Given this list of marker genes Anapc15, Anapc10, Anapc16, Cdc26, Anapc7, Fzr1, Ube2s, Anapc4, Cdc23, Anapc5, Ube2e1, Cdc14a, Anapc11, Cdc16, Cdc20, Anapc2, Cdc27, Ube2c, Anapc1, Ube2d1, here is a description of the gene set: Conversion from APC/C:Cdc20 to APC/C:Cdh1 in late anaphase Mouse Gene Set: REACTOME_CONVERSION_FROM_APC_C_CDC20_TO_APC_C_CDH1_IN_LATE_ANAPHASE species: Mus musculus